Given this list of marker genes RUFY3, AP2M1, TLR3, AP2S1, TLR7, AP2A2, RUFY4, CTSS (cathepsin S), TLR9 (toll like receptor 9), CLTA, ATG16L1, CTSL, AP2A1, LDLR (low density lipoprotein receptor), TASL, LGMN, SLC48A1, ABCB6, SLC15A4, TLR8, PRKCD, TPCN2, PCSK9, RNF167, TPCN1, CLTC, SMPD1, CTSK, AP2B1, CTSB, here is a description of the gene set: An transient hybrid organelle formed by fusion of a late endosome with a lysosome, and in which active degradation takes place. studied in species Homo sapiens Human Gene Set: GOCC_ENDOLYSOSOME